Given this list of marker genes PAK4, NGFR, PRPH2, PRSS3, SULT1C2, NTRK2, PRKG2, MACROH2A1, FABP7, PJA1, HOPX, CTSG, EDDM3A, STAT4 (signal transducer and activator of transcription 4), INSL5, MTMR7, NR6A1, RAB33A, DNM3, TARP, MEFV, DPYD, PPME1, SOAT2, PEX5L, F2RL1, ASB9, TRA2A, ESR1, CLDN10, WDR11, SCRG1, ALDH1A1, PIPOX, HAND1, EN2, SPART, AUNIP, NBL1, ENGASE, BTG4, SPINK2, RYR3, TMEM8B, LRRN3, UGT2B15, TMEM53, EFEMP1, AKAP5, ATRNL1, DHX32, EDAR, IL12RB2, ZNF507, DRAM1, ZNF835, SELP, MS4A1, RAD51AP1, DCN, SYNDIG1 (NCBI Gene Id 79953), ASB13, LEPR, IL1B, FNDC8, SAYSD1, DPEP2, NEUROD4, JAM2, CCNYL7 (NCBI Gene Id 100419017), SMARCD1, ZSCAN31, NTRK3, ATP2B2, HHLA1, CHRNB3, ELK3, MTCP1, IGLJ3, SCD, PRL, SFRP1, KCNMB1, HPGDS, CDC42EP4, GNA14, RPS29, TNIP3, TSBP1, OGFRL1, TSPAN32, NOS1AP, RNF208, OR7A5, VWA5A, RHAG, HJURP, FLT1, LRP4, SKA1, LLGL1, GLDC, DCBLD2, SLC13A3, GSTM2, BST1, SPAG5 (NCBI Gene Id 10615), CDH11, SOCS6, TP63, PLIN1 (NCBI Gene Id 5346), ACADL, BMAL2, SLC39A9, ATG10, PLD1, LRRC49, SAP30L-AS1, CLEC11A, ACACB, LINC02981, RNF39, TBC1D29P, PLLP, CD160, SMR3B, ANOS1, PPP2R3A, PAM, PLA2G5, ATXN8OS, DHRS11, MMP2, CAVIN1, TRPC1, CRISPLD2, TRPM3, UNC45A, TEK, EPHA1, EFNA5, PTCH2, DNAI4 (dynein axonemal intermediate chain 4), PFKFB1, GIMAP4, HAUS5, PLPPR1, LCP2, GJA1, SLIT2, HFE, OPA1, NR1H4, ERI2, PSG7, SOX30, OR2B2, RPL36A, MAOB, HOXD1, ZIC4, IL12B, NCR1, ITGA5, TOP3B, GUCY1B1, LGALS14, EHD2, PRSS8, GRM6, CAV1, BCL2A1, ADGRG2, RASSF7, SPRY4, HPX, GNAQ, TPH1, HCRT, ANKRD6 (ankyrin repeat domain 6), CCHCR1, ERI3, DOCK1 (dedicator of cytokinesis 1), ATN1, STAB1, DNAI7, ZPBP, SLC38A4, SHC3, GNAT2, KIR3DL3, CLIC4, ESRP1, NELL2, ZNF747, ALDH1B1, ZC2HC1C, here is a description of the gene set: Genes down-regulated in macrophages (12h): rosiglitazone and IL4 versus IFNG and TNF. studied in species Homo sapiens Human CD14 positive monocytes were purified from healthy volunteers’ blood and cultured in vitro for 4, 12, 24, 72 hours. While culturing, macrophages were activated alternatively with interleukin-4 (IL-4 100 ng/ml) or classically with interferon-gamma (IFNg 100 ng/ml)+tumor necrosis factor (TNF 50 ng/ml) or left without activation. Simultaneously, macrophages were also treated with vehicle (DMSO:ethanol) or 1mM synthetic PPARg agonist, Rosiglitazone. We used Affymetrix microarrays (U133Plus 2.0) to analyze activation and PPARg-induced gene expression changes. Human Gene Set: GSE16385_ROSIGLITAZONE_IL4_VS_IFNG_TNF_STIM_MACROPHAGE_DN from publication Szanto A, Balint BL, Nagy ZS, Barta E, Dezso B, Pap A, Szeles L, Poliska S, Oros M, Evans RM, Barak Y, Schwabe J, Nagy L (PMID 21093321)